Given this list of marker genes SLC12A4, UBE3B, MMP25, TAFAZZIN, PFKFB2, TSPO2, NDST1, MVK, KHNYN, DGCR11, RBM8A, ITGAD, NUDT3, MPP2, ADAMTSL2, B4GALT3, ARSL, M6PR, TCOF1, GTF2F1 (NCBI Gene Id 2962), DRG2, USP19, ARVCF, RPA2, IFT140, TMEM94, LSM12, PTPN9, GPR161, PLEKHG3, CAMK2B, RAP1GAP2, PSD4, VAMP1, PKMYT1, AMELX, HTR2A, TGFB1, CNOT4, ENTREP3, MGAT1, ADSL, USP11, ZFPL1, LMTK2, ZBED1, TRA2A, ARHGEF1, SIK3, PRKCSH, PITPNM1, XRCC2, KAT7, SLC22A24, ACR, SNW1, CRYBA4, TPMT, PCBP3, ODF1, IGHMBP2, GSK3A, GPR35, KCNH2, ITGA10, ORC1, ZNF337, KIF21B, GHITM, PAX8, FZR1, CNP, FKBP15, ARAF, RXRB, LINC00928, PTGER3, CNTN1, HSF4, EFNA3, PRPH, P2RY11, ANKRD12, KIF1C, CASP2, CNPPD1, GLP1R, PAIP2B, TUB (NCBI Gene Id 7275), EML3, GPA33, H6PD, CELA2A, NHERF2, GRK2, IKBKG, ADAM15, PFDN1 (prefoldin subunit 1), LYZL6, APOBEC3C, IGSF9B, ZKSCAN3, TNK2, MOK, PDPK1, ACKR2, PNMT, GPRIN2, here is a description of the gene set: Neighborhood of CNTN1 contactin 1 in the MORF expression compendium Human Gene Set: MORF_CNTN1 Neighborhood of CNTN1 species: Homo sapiens